Given this list of marker genes Agtr1b, Agtrap, Agtr2, Agtr1a, Mas1, Mrgprh, here is a description of the gene set: Combining with angiotensin to initiate a change in cell activity. species: Mus musculus Mouse Gene Set: GOMF_ANGIOTENSIN_RECEPTOR_ACTIVITY